The following is a description of a gene set: species: Mus musculus A transcription termination process that completes the production of a primary RNA polymerase II transcript. Mouse Gene Set: GOBP_TERMINATION_OF_RNA_POLYMERASE_II_TRANSCRIPTION, and this is the list of marker genes: Ssu72, Setx, Scaf4, Maz, Pcf11, Zgrf1, Wnk1, Xrn2, Scaf8